Given this list of marker genes NEIL2, POLI, POLK, RFC2, RAD51, RFC5, PMS2, MSH2, REV1 (REV1 DNA directed polymerase), TDG, FANCL (FA complementation group L), RAP1A, POLE4, POLD4, POLD3, NHEJ1, RFC1, MUTYH, RAD23B, MBD4, PARP2, BRIP1, RFC4 (replication factor C subunit 4), ATM, PRKDC, POLB, MPG, RPA3, RPA2, XPA, POLE, ERCC2, FANCI, MNAT1, RAD50, SMUG1, EXO1, CUL4A, RBX1, USP1, WRN, DDB2, ERCC6, RAD52, GTF2H2C, GTF2H4, ATR, GTF2H1, GTF2H2, LIG1, CENPX, BRCA1, LIG3, CENPS, NBN, POLH, FAAP100, CCNH, BRCA2, FANCE, PALB2, FANCD2, XRCC1, PCNA, POLE2, UNG, RAD54B, POLD1, OGG1, RPA1, APEX1, CUL4B, MSH6, POLL, FANCB, FANCA, DDB1, FANCM, FANCG, RFC3, RAD51C, CDK7 (cyclin dependent kinase 7), WDR48, NTHL1, POLM, MRE11, FANCF, H2AX, FANCC (NCBI Gene Id 2176), PARP1, MGMT, MSH3, XPC (XPC complex subunit, DNA damage recognition and repair factor), CHEK1, PNKP, LIG4, ERCC1, POLE3, FEN1, REV3L, GTF2H5, MLH1, XRCC6, APEX2, XRCC5, ERCC3, ERCC4, HMGB1, NEIL3, ERCC8, DCLRE1C, POLD2, XRCC4, FAAP24, FAN1, GTF2H3, CETN2, TERF2, RAD23A, ERCC5, here is a description of the gene set: Human Gene Set: WP_DNA_REPAIR_PATHWAYS_FULL_NETWORK DNA repair pathways, full network studied in species Homo sapiens